Given this list of marker genes Scarb1, Cd14 (NCBI Gene Id 12475), Tlr4, Ly96, Ptafr (platelet-activating factor receptor), here is a description of the gene set: studied in species Mus musculus Combining with a lipopolysaccharide and transmitting the signal across the cell membrane to initiate an innate immune response. Lipopolysaccharides (LPS) are major components of the outer membrane of Gram-negative bacteria, making them prime targets for recognition by the immune system. Mouse Gene Set: GOMF_LIPOPOLYSACCHARIDE_IMMUNE_RECEPTOR_ACTIVITY